Given this list of marker genes CIB2, NR2E3, OPA1, PEX3, AHR, PDE6G, HKDC1, KIZ, PDE6B, ARHGEF18, AKT1 (NCBI Gene Id 207), KCNV2, CLCN2, PEX11B, MSH6, IDS, MTOR, RPGR, SH3TC2, PEX7, PEX2, BBS1, TRAF7, CNGA3, ITM2B, GNAQ, PRPF4, AMACR, TTLL5, GRK1, CNGB3, GPR101, MUTYH (mutY DNA glycosylase), MSX2, PDZD7, IMPG1, PEX14, CERKL, SDHA, MERTK, MCAT, SLC7A14, KIF3B, GUCA1B, PDE6C, ALMS1, CA4, MT-ND4L, ADA2, TUBB3, RPS20, FDXR (ferredoxin reductase), FXN, C1QTNF5, COL3A1, CFH, MMP19, AGBL5, BAP1, EFEMP1, SEMA4A, WFS1, BRCA2, GNAT1, MECR, PEX26, HK1, MIEF1, YARS1, CRB1, ATP1A2, MT-TW, PCDH15, NEK2, AIP, ATF6, SLC6A6, KIAA1549, PIK3CA, RP1L1, HLA-B, PEX6, USH2A, GNAT2, MSH2, THPO, CFI, CRX, PRPF31, MT-ND2, OAT, MLH1, HLA-A, CYP1B1, TMEM126A, CDHR1, MEN1, NDUFS2, BTD, RIMS1, MT-TS2, USP48, MPL, CACNA1F, PEX13, NR2F1, CTNNB1, THSD1, OPN1LW, IFT172, RP1, PRPF6, COL18A1, USH1C, ENG, PHOX2A, POMGNT1, RPGRIP1, KRAS, NRL, FLVCR1, ARL3, IFT88, ARL6, PCARE, WHRN, CNGA1, CCDC28B, DNM1L, ATRX, COL25A1, PMS1, CEP78, CHM, BBS2, MFSD8, PRPF3, IFT140, ZNF408, IBA57, PEX19, ADGRV1, CFAP418, TGFBR3, TIMM8A, POC1B, RGR, SETD5, MT-TV, RHO, CFAP410 (NCBI Gene Id 755), ZNF513, MT-TL1, OPN1MW (opsin 1, medium wave sensitive), TRNT1, AIRE, AHI1, TTC8, RAX2, POLE, RRM2B, MT-TK, CC2D2A, ASB10, MT-ND1, ESPN, GUCY2D, MT-ATP6, UNC119, SUFU, IMPG2, TREX1, PRRT2, SOST, VCAN, DHDDS, PEX10, SCAPER, MT-ND6, LZTR1 (NCBI Gene Id 8216), NF2, PEX5, SAG (NCBI Gene Id 6295, S-antigen visual arrestin), IDH3A, EYS, TOPORS, SMARCB1, TERT, CYP4V2, TGFBR2, NR3C1, MT-TQ, RBP3, IDH3B, BRAF, OFD1, FA2H, MT-CYB, ELOVL4, PEX12, PITPNM3, RP9, USP8, POLG, POU3F4, PRPH2, MT-CO1, RDH12, ACO2, MT-ND4, PEX16, DNAJC30, ELOVL1, MYO7A, MT-TC, AKT3, AIPL1, MT-CO2, SLC25A46, COL4A1, MAK (NCBI Gene Id 4117), RAB28, PDE6A, DRAM2, CNNM4, CACNA2D4, SH3BP2, HGSNAT, SMO, KIF21A, SAMD7, HLA-DRB1, BMPR1A, ARSG, RDH5, PRCD, RP2, REEP6, TUBB2B, OPA3, PTPN22, RLBP1, P4HA2, CLRN1, SCN1A, ATM, RPE65, ARL2BP, PEX1, DLAT, POLD1, TUBA1A, RNU4ATAC, SMARCE1, RTN4IP1, MTTP, PROM1, ABCA4, CHEK2, SPATA7, KLHL7, PDE6H, MT-ND5, KCNJ13, LCA5, MT-TF, RDH11, EIF2B3, DHX38, PMS2, BEST1, ANGPTL6, MTRFR, TLCD3B, PRPF8, CACNA1A, NMNAT1, MYOC, FAM161A, FSCN2, CNGB1, USH1G, SNRNP200, AARS1, TP53, LRAT, ROM1, MT-CO3, GUCA1A, CDH23, ADAM9, TIMP3, TULP1, MFN2, EPCAM (epithelial cell adhesion molecule), CWC27, IMPDH1, TUB, PDGFB, HARS1, JAK2, PRORP, here is a description of the gene set: Human Gene Set: HP_VISUAL_FIELD_DEFECT Visual field defect species: Homo sapiens